Given this list of marker genes Zfp626, Ppp2r3c, Riok1, Cacna2d3, Minpp1, Zfp942, Radx, Zfp607b, Pals1, S2bpcox16, Cpeb4, F2rl1, Hyal4, Zfp882, Cyc1, Usp28, Pbx1, Strn4, Eif4ebp2, Il17ra, Synpo2, Aak1, Chrdl1, Vps35, Zfp280d, Plcl1, Reps2, Zfp820, Pcmt1, Map1b, Pate5, Zfp940, Zc2hc1b, Zfand6, Cysltr1, Wasf2, Fxr1, Rex2, Thpo, Ptprt, Raph1, Ift140, Aktip (NCBI Gene Id 14339), U2surp, Ncapg2, Prlr, Impa2, Cxcl15, Cox16, Dcun1d1, Hnrnpa0, Ccnd3, Macrod2, Arpp21, Zfp994, S1pr1, Tcf12, Krtap6-3, Hhex, Crp, Ddx4, Synj2bp, Gm5916, Peli2, Tbc1d15, Pde1c, Flvcr1, Zfp980, Card10, Crhr1, Aspn, Spag9, Klrc1, Mospd2, Abtb2, Acvr2a, Hpgds, Zfp600 (zinc finger protein 600), Mybpc2, Pdzd8, Ndufaf5, Nrk (NCBI Gene Id 27206), Prkar2b, Zscan12, Zfp981, Elavl4, Agtr2, Tln2, Dclk1, Samd4, here is a description of the gene set: from publication Chen Y, Wang X (PMID 31504780) Mouse Gene Set: MIR_7227_5P Genes predicted to be targets of miRBase v22 microRNA mmu_miR_7227_5p in miRDB v6.0 with MirTarget v4 prediction scores > 80 (high confidence targets). studied in species Mus musculus